The following is a description of a gene set: Mouse Gene Set: GOBP_FOREBRAIN_CELL_MIGRATION The orderly movement of a cell from one site to another at least one of which is located in the forebrain. species: Mus musculus, and this is the list of marker genes: Rhoa, Dixdc1, Dab1, Dab2ip, Ulk4, Cxcl12, Tnr, P2ry12, Mdga1, Adgrg1, Ogdh, Gli3, Socs7, Nrg3, Fbxo45, Efhc1, Ctnnb1, Fgf13, Pou3f2, Dcx, Tyro3, Disc1, Sun1 (NCBI Gene Id 77053), Cdk5, Drd2, Cxcr4, Nkx2-1, Nr2e1, Zmiz1, Axl, Cntn2, Col3a1, Lrp8 (low density lipoprotein receptor-related protein 8, apolipoprotein e receptor), Slit1, Rtn4, Bmerb1, Cdk5r2, Lrp6, Mboat7, Cdk5r1, Nrg1, Ccdc141, Pafah1b1, Syne2, Foxb1, Sun2, Drd1, Ndel1 (nudE neurodevelopment protein 1 like 1), Robo1, Emx2, Arl13b, Rnf7, Htr6, Egfr, Pex13, Srgap2, Fut10, Lrrk2, Fgfr1, Foxg1, Srf, Cul5, Rac1, Wdr47, Lhx6, Psen1 (NCBI Gene Id 19164), Pou3f3, Lamb1, Arx, Slit2, Fezf2, Pex5, Reln